Given this list of marker genes STAT4, EREG, ITGBL1, EPHA3, EOGT, COL8A1, FAM9C, L1TD1, COL4A1, TEX14, AICDA, MYO3B, MYOCD, ZNF716, TIMD4 (NCBI Gene Id 91937), SMAD3, SCN11A, OR10K2, RHOH, CYSLTR2, FYB2, TEX101, MFSD4B, APOL1, ARHGAP28, DDO, NAT1, PLA2R1 (NCBI Gene Id 22925), EML6, SLC9A4, ABCC9 (NCBI Gene Id 102724274), BVES, RSAD2, H2BC15, HTR3B, CD22, CPA4, STEAP2, NEK7, KIAA1328, LINC01550, TBC1D8B, NIPAL1, BEST3, PLXNA4, TNFSF10, TMC7, SGCD, TCAF2, CCDC190, ELF5, SNX24, ZIM3 (NCBI Gene Id 114026), PDE3A, BEND7, NEBL, NUAK2, GPR157, FRK, TTC39B, STIL, ZNF221 (NCBI Gene Id 7638), BNIPL, S100A2 (NCBI Gene Id 6273), OR10K1, LAIR1, PARP14, INSM1 (INSM transcriptional repressor 1), ZNF492 (zinc finger protein 492), PAX3, AMY1B, SLC36A2, CIMIP5, TESPA1, AIPL1, SLC14A2, NNMT, NRP1, ZFP42, ECT2, ADRA1A, SLFN12L (schlafen family member 12 like), IRAG2, GLIPR1L2, GPR151, ARHGEF28, FGF5, CCNF, BRS3 (NCBI Gene Id 680), KCNG3, MINAR2, ENAM, SPZ1, CGNL1, REL, MAP1LC3C, SV2C, CLMN, OAS2, CADPS2, LRRC36, ZNF705G, MRPL42P1, CHRDL1, CD96, HES2, GLYATL1, MYPN, FCRL4, SP140L, ERAP2, C4orf36, SLC22A24, ERVW-1, ADAMTS9, STC1, VAV3, DNAJC12, NDUFV1-DT, FAM177B, OR1N2, PDE7B, APCDD1, CFAP97D1, JAML, SLC14A1, GCNT3 (glucosaminyl (N-acetyl) transferase 3, mucin type), ANKRD55, GBP6 (guanylate binding protein family member 6), ESRP1, E2F7, S100Z, FBLIM1, WDR31, TPRG1, EBF1, ACAN, UGT2B15, PLXDC1, TM4SF1, RARB, BNC1 (NCBI Gene Id 646), MBNL1, FOXP2, CNBD2, ADTRP, CDHR4, GADL1, TOGARAM2, EOMES, OR3A1, SELL, SLC10A1, SELE, FAM83D, IRF6, HRK, ADGRL4, TERB1, C21orf58, DOCK5, CDCP1, OR5H6, TM4SF19, SLC6A4, PRSS40A, LINC01553, SCIMP, ABCA9, ROR1, RGS5, IRF1, PCDH18, LAMB4, EHF, DSC3, PPM1H, NPY2R, TES, C7, TTC6, CUX2, SHROOM4, PPARGC1A, LYZ, CEP55, AGMO, TRIM66, PCDH11Y, HFE, SPANXN1, SHISA9, LINC02860, ENSG00000187951, MARVELD2, SAPCD2, SFMBT2, OR8K1, ADAMTS4, OR4K2, PENK, TLR3, IFNA6, AKR1D1, CXXC4, CRB1, CRX, ACVR1C, WNT5A, MACC1, AHSP (alpha hemoglobin stabilizing protein), PRRG4, GAB3, C1QTNF7, SULT1C2, PTPN14, SAMD7, SERPINB5, DMC1, LINC02864, XKR9, KBTBD12, SLC17A6, SERPINA5, MCOLN3, SLC28A2, CLNK, CPNE8, FUT6, LRRC38, LEAP2, MORC4, NEUROD4, TSBP1, GRK7, WFDC8, HSPA2, KCNE4, PCTP (NCBI Gene Id 94001), PARP15, SCGB2A2, CLEC12A, VSIG1, CELA3A, KNL1, CEACAM1, APOBEC3A, PGA3, LAX1, KCNJ15, SIX4, TTN, GPC5, TECRL, ARHGAP24, PTPRJ (NCBI Gene Id 5795), MRAP2, OPHN1 (NCBI Gene Id 4983), TMEM236, CFAP54, POM121L7P, SYNPO2 (NCBI Gene Id 171024), ABCB5, SULT2A1, RHAG, MUC22, GREB1, CHDH, IL1RL1, PPP1R17, PDE4C, LEUTX, SDR16C5, YES1, EBPL, ASPA, UPK1B, OR10J3, HTR4, MGAT4EP, ODAPH, CTCFL, CLEC1B, ACOT11, PYHIN1, ITGB7, IYD, BLOC1S6, HTR2C (NCBI Gene Id 3358), CENPI, ZFP57, ZBTB8B, BNC2, IL5RA, ADAMTS6, CPT1A, PIF1, RNASEL, APOLD1, CRABP1, FOXN4, ISG20, HHAT, GPR83, KRTAP15-1, FAM241A, ACSL6, CCR8, CCR2, VSTM4, TMEM212, OR52A5 (olfactory receptor family 52 subfamily A member 5), WDR93, CNKSR3, MSRB3 (methionine sulfoxide reductase B3), SLC17A4, NPFFR1, LINC02108, ORC4, SLC38A11, KRTAP24-1, NFATC2, COL28A1, E2F2 (E2F transcription factor 2), LGSN, BPIFC, SULT1B1, TMEM154, KLRD1, CALCR, MAB21L3, ADGRL2, OR8D4, FLT1, OLFML1, PDE6A, CCDC150, CXCL9, SPN, ABCG5, GIMAP1, ACSM2B, COBL, CCDC168, AXDND1, TRIM22, DPPA4, MEFV, BMPER, ASB15, HSD17B13, POU5F1B, SASH1, KANK4, SYT9, PPP1R3B, IFNLR1, WWTR1, GDF5, OPRK1, ZNF608, OR4D5, ICAM2, TDRD1, RNASE11, GATAD1, SLC16A12, RNF125, THBS1, ASCL1, APOL6, LAMC2, PAMR1, FMOD, C5AR2, PIWIL3, SHE, PLB1, TRIM58, TEX38, SAMD5, ETS1, POU2AF1 (POU class 2 homeobox associating factor 1), here is a description of the gene set: Human Gene Set: FLORIO_NEOCORTEX_BASAL_RADIAL_GLIA_UP Genes up-regulated in basal radial glia (bRG) relative to apical radial glia (aRG), and up-regulated in both aRG and bRG relative to neurons. from publication Florio M, Albert M, Taverna E, Namba T, Brandl H, Lewitus E, Haffner C, Sykes A, Wong FK, Peters J, Guhr E, Klemroth S, Prüfer K, Kelso J, Naumann R, Nüsslein I, Dahl A, Lachmann R, Pääbo S, Huttner WB (PMID 25721503) species: Homo sapiens Evolutionary expansion of the human neocortex reflects increased amplification of basal progenitors in the subventricular zone, producing more neurons during fetal corticogenesis. In this work, we analyze the transcriptomes of distinct progenitor subpopulations isolated by a cell polarity-based approach from developing mouse and human neocortex. We identify genes preferentially expressed in human apical and basal radial glia that lack mouse orthologs. Among these, ARHGAP11B has the highest degree of radial glia-specific expression. ARHGAP11B arose from partial duplication of ARHGAP11A (which encodes a Rho guanosine triphosphatase-activating protein) on the human lineage after separation from the chimpanzee lineage. Expression of ARHGAP11B in embryonic mouse neocortex promotes basal progenitor generation and self-renewal and can increase cortical plate area and induce gyrification. Hence, ARHGAP11B may have contributed to evolutionary expansion of human neocortex.